The following is a description of a gene set: from publication Szanto A, Balint BL, Nagy ZS, Barta E, Dezso B, Pap A, Szeles L, Poliska S, Oros M, Evans RM, Barak Y, Schwabe J, Nagy L (PMID 21093321) C57Bl/6 wild-type and STAT6 KO mice were used to study PPARg and IL-4 signaling. Bone marrow of 3 mice per group was isolated and differentiated to macrophages with M-CSF (20 ng/ml). 20 ng/ml IL-4 was used to induce alternative macrophage activation and 1 uM Rosiglitazone (RSG) was used to activate PPARg. From each mouse 4 samples were generated: 1. M-CSF, 2. M-CSF+RSG, 3. IL-4 and 4. IL-4+RSG. All compounds were added throughout the whole differentiation process, and frech media was added every other day. Control cells were treated with vehicle (DMSO:ethanol). After 10 days, RNA was isolated and gene expression profiles were analyzed using Mouse Genome 430 2.0 microarrays from Affymetrix. studied in species Homo sapiens Genes down-regulated in bone marrow-derived macrophages with STAT6 knockout: control versus treated with IL4 and rosiglitazone. Human Gene Set: GSE25088_CTRL_VS_IL4_AND_ROSIGLITAZONE_STIM_STAT6_KO_MACROPHAGE_DN, and this is the list of marker genes: RET, ZNF707, UBE2Z, TRIM38, PABIR1 (NCBI Gene Id 116224), PARP10, MIDEAS, ADNP2, DMTF1 (cyclin D binding myb like transcription factor 1), HCRT, SLCO5A1, EMG1, LLGL1, ADPRS, BANP, SPATA31F1, H2AC6, ABCC10, CDK2, MIR22HG, GIPC1, ILF3-DT, TMEM209, RPUSD1, FGF2, FAM199X, THEMIS2, LSG1, LINC00163, BRME1, MRPL18 (NCBI Gene Id 96273), NTF4, SLC8A1, EFTUD2, HNRNPF, DPYS, FBXO22, TOR1B, XPO1, TMEM41A, CCDC59, HLA-E, NT5C1B, FMNL1, KPNA2, GGCX, SEMA6B, KCTD19, VOPP1, KRBA2, C22orf15, NECTIN2, BST2, IL15, S100A11, IL18RAP, LINC01121, RETREG1, OTX1, NFX1, SPDL1, CDT1 (NCBI Gene Id 81620), GTF2E1, AP5Z1, MYO19, LSMEM1, MFN1, GUCA2A, MTMR4, AKNAD1, LINC01532 (NCBI Gene Id 100508327), IL4I1, ZNF346, CFAP206, CCDC142, CSTF2, KYNU, KATNIP, NLRP7, TSR2, MRPS18C, TSGA10IP, PDE4DIP, PNMA3, RAB8A, SLAMF7, FBXL12, EXOSC3, ZNRD2 (NCBI Gene Id 10534), RANGRF, DAXX, HLA-K, RNF114, PARP12, NFE2L1, SLFN13, SERPINA12, BUB1B, ELL2, PAX3, XRCC2, LEPROTL1, LINC00683, POR, PTPRN2, PCBP1, ZNF267, UQCC6, PSMA3, MIA3, ZNF350, TMEM87A, MX1, DEXI, GOPC, EXOSC10, EHHADH, NPFFR1, AJAP1, FAM222B, ORC3, NOTUM, UBE2DNL, EN1, HLA-C, BOC, TRIM5, S100A7, CNOT9, MED26, TESMIN, PSME3IP1, MAMDC4, CCDC137, FMR1, TBR1, CD70 (NCBI Gene Id 970), EIF5, EPSTI1, LINC02003, DDX60L, FANCL, EBI3, MAP7D1, LGALS3BP, CUL7, H2BC6, ZSCAN16, PPID, GCH1, IER5, KDM2A, ISCU, ABTB2, SLC34A1, RELA, PARP15, MCM3, AGRN, LINC00475, TTLL11, HSP90AA1, PDCD7, BATF2, HAND2-AS1, TYMP, STIM2, MYL12A, RNF31, HECW1-IT1, ISG20, DCAF15, ATP6V1G1, RBM28, CRYBB2P1, PPFIA2, SELENOS, STAM, HAO1, SAMD9, TBPL1, MICU2, BTN3A2, SLC9A1, TRIM6, MRM3, SEZ6L2, SUPT4H1, TMOD4, PPM1K, FAM240C (family with sequence similarity 240 member C), H2BC21, ZNF766, SLC31A2, AMZ2P1